Given this list of marker genes TMEM50A, JADE2, HLA-DMA, RIOK3, CTSS, ENO3, MPC2, KCNS3, FZD5, PKIG, PTCD1, RAB5IF (RAB5 interacting factor), EPB41L5, ALKBH1, KCNJ12, PASK, ELP3, ULK2, BACH1, FBLN2, ZNF136, PTPN7, UBA5, YBX3, MLF1, MEF2C, SDC1, PRORP, BAK1 (NCBI Gene Id 578), RABIF, HSPB7, MPI, RBMX2, HOXB2, JADE3, U2SURP, VCPIP1, MRPL39, APH1B, MNAT1, OLFML3, MFSD13A, EPB41L4A, AK1, ZNF212, IL10RA, CUEDC2, GUCY1B2, HSPBP1, POU3F1, SEMA4G, MALT1, ACY1, ARHGAP10, RCAN1, DNAJC8, IRF9, GCH1, CTF1, PFDN1, SNX24, CMAHP, IRF8, KLHL25, COX6A1, RPAP2, ZNF446, PALS2, TMEM39B, PYCARD, CYBA, ARID5A (AT-rich interaction domain 5A), EIF4G3, F8, SLC39A8, TBC1D15, FLII, SERPINB1, CST2, PLAGL1, RAB11FIP2, GPN2, DYNC2H1, OPLAH, PEX3, CREBL2, LY75, GNGT1, BNIP1, KATNA1, CDC37 (cell division cycle 37, HSP90 cochaperone), BCL2L13, MTREX, CD3G, PTPRR, ZNF200, TTC17, OBSL1, SMARCAL1, ST7L, LINC00667 (long intergenic non-protein coding RNA 667), C1QL1, PPP1R3D (protein phosphatase 1 regulatory subunit 3D), NDUFC1, ALDH3A1, AARS1, ACBD4, LMF1, SENP3, POFUT1, SSTR2, FAM163A (family with sequence similarity 163 member A), SDCBP, MRPL23, NAB2, OR12D2, PPP2R1A, RAD1, MRPL2, BTN3A1, DPP4, CCDC106, IRF1, PEX13, CWF19L1, LLPH, FOXN2, SFMBT1, PSMB7, SCAND2P, ZBTB40, IBA57, CAMKMT, KANK3, GALK1, PIGV, PSMD9, TMEM186, SCYL3, C14orf93, KCND1, VPS26A, CHRNA10, ELF4, UBIAD1, KATNIP, TCFL5, IGFALS, PADI2, SLC35F6, EIF2D, OCRL, C1GALT1, GTF2B, TXNL4B, SNAP29, MBD2 (NCBI Gene Id 8932), HS3ST2, CLDN7, HHAT, SPATA2L, THG1L, PROX1, ASGR2, EIF1AY, SOCS2, CSF1, GPAA1, HIF1A, CADM3-AS1, FAM184A, H2BC10, ZHX2, ZNF529, UXT, TEX30, LTB, KATNB1, SLC24A1, NCK2, TMEM268, TRAPPC4, NUP42, NRIP1, PODXL2, TLN2, STARD5, KPTN, MCMBP, ZNF669, BBS10, LGALS13, GVINP1, SYNE1, STX12, TIPIN, SCN10A, NKX3-1, here is a description of the gene set: species: Homo sapiens Genes down-regulated in CD4 T cells treated with pioglitazone and over-expressing: FOXP3 and PPARg2 isoform of PPARG versus FOXP3. from publication Cipolletta D, Feuerer M, Li A, Kamei N, Lee J, Shoelson SE, Benoist C, Mathis D (PMID 22722857) Human Gene Set: GSE37533_PPARG2_FOXP3_VS_FOXP3_TRANSDUCED_CD4_TCELL_PIOGLITAZONE_TREATED_DN We identified Pparg as a major orchestrator of the phenotype of adipose-tissue resident regulatory T cells (VAT Tregs). To explore the contribution of Pparg1 and 2 in the generation of the VAT Tregs-specific gene signatures, CD4+FoxP3- T cells were transduced with Foxp3+/- Pparg1 (or Pparg2), treated with Pioglitazone or vehicle, and double sorted for microarray analysis.